The following is a description of a gene set: Human Gene Set: NEUROG3_TARGET_GENES from publication Yevshin I, Sharipov R, Kolmykov S, Kondrakhin Y, Kolpakov F (PMID 30445619) studied in species Homo sapiens Genes containing one or more binding sites for (NEUROG3) in their promoter regions (TSS -1000,+100 bp) as identified by GTRD version 20.06 ChIP-seq harmonization., and this is the list of marker genes: HOXA-AS3, RBM33, RBM33-DT, HEXIM1, MIR4512 (NCBI Gene Id 100616149), RPL36, RNVU1-22, RNVU1-19, CENPU, POLK, IRF2BP2, RAB5IF, KATNBL1, PURA, MALINC1, PTPN2, TMX1, SUMF2, DHRS4-AS1, DUSP12, MAST4, NOL7, DELE1, SNAPC5